Given this list of marker genes STAG2, DCAF12L2, UBE2V1P16, BTG3P1 (BTG anti-proliferation factor 3 pseudogene 1), H3P47, RPS26P57, RPS26P56, RUVBL2P1, STAG2-AS1, PRR32, GRIA3, MTND4LP1, DCAF12L1, CHCHD2P1, NPM1P34, RNU7-69P, THOC2, ENSG00000212321, TENM1 (teneurin transmembrane protein 1), ENSG00000237208, ACTRT1, RPL32P35, KRT18P44, ZIK1P1, RNA5SP513 (NCBI Gene Id 100873564), ACTRT1P1, SH2D1A, MEMO1P4, TEX13C, MTCO1P53, RPL7AP72, PARD6BP1, FBLIM1P1, MTCYBP38, PNPLA10P, XIAP-AS1, TPT1P13, RPL3P12 (ribosomal protein L3 pseudogene 12), RN7SL190P, TUBB4AP1, MTND4P24, FERP1, RNU6-122P, TJAP1P1 (TJAP1 pseudogene 1), TEX13D, XIAP, HSPA8P20, MRRFP1, here is a description of the gene set: Human Gene Set: chrXq25 species: Homo sapiens